Given this list of marker genes ARK2C, PDE4D, LXN, EGLN3, ADGRF1 (NCBI Gene Id 80118), ALDH1A2, PLPP5, GPD2, FYB1, DNAH9, DDIT4, SLC7A2, TMEM45A, AGRN, HLA-DOA, RNF19B, SP3, PFKL, MYCBP, SUCO, SMIM3, PTGFR (NCBI Gene Id 5737), DCN, SEMA4C, RPS6KA4, AQP9, SOD2, GARIN3, HIVEP3, HCAR1, OSBPL3, SAA2, BCKDHB, SMIM6, C6orf15, FCGR2B, ARRDC4, ZNF264 (zinc finger protein 264), GFOD1, RAD54L, MKS1, MLLT11, TNF, SLC4A7, TRIM7, PRR15, UBE2R2, JARID2, RIN1, FABP1, TMBIM4, CCSER1, ATP5ME (ATP synthase membrane subunit e), SUSD2, ABCB4, CFHR1, FAM162A, PIK3CG, KCNF1, KCTD11, F3, CLEC5A, PILRB, CA12, SSTR5, MAK16, MRPL45, FAM167B, CD14, PRKAR2B, DMXL2, SCHIP1, GPR35, CHIC2, SEMA7A, CD40, OR2C1, PTPN6, FKBP14, GNG10, LIF, ELL2, C19orf81, LUM, AHRR, SLC20A1, PTGES, CA4, AXL, FPR1, RAB27A, LOXL3 (NCBI Gene Id 84695), DSN1, MRPL52, MMS22L, NGF, FOXF2, ADAMTS7, SLC26A4, GLRX, S100A8, NKAPL, JAG1, METTL24, ZNF175, MMP2, DSTN, AK4, SAA1, CPB2, CFB, STX11, COL5A3, PILRA, SERPINB9, NFKBID, TOP1MT, DTX2 (NCBI Gene Id 57652), PMP22, SH3BP4, RCL1, USP53, PFKFB3 (6-phosphofructo-2-kinase/fructose-2,6-biphosphatase 3), ZNF771, UNC13C, ABHD16B, OPN1SW, PM20D1, GINM1, EDIL3, SRSF11, FBXO31, SRGN, NT5E, CNOT2, ABCA8, JMJD6, BTG3, CAVIN4, SOCS1, SLAMF9, VEGFA, MASTL, ACOT12, RPS27, GK, MAP3K12, NIPSNAP1, SPIN4, LRRC8D, MYL10 (NCBI Gene Id 93408), FJX1, RAP1GAP2, TMEM70, SAXO1, PRKAR1B, TNFAIP6, CST7, MCF2 (NCBI Gene Id 4168), EIF4E3, SNORC (secondary ossification center associated regulator of chondrocyte maturation), PRMT1, FBP1, ACOT7, HCLS1, PLCB3, CAND2, RUVBL2, AFF3, RDH12, HRG, BNC2, TCEA1, BMP1, HERC6, TGM1, IL1RN, CD72, DNAAF1, RBFOX1, SLC1A2, DGAT2, REL, MUC1 (NCBI Gene Id 4582, mucin 1, cell surface associated), TMA16, SGCE, MEX3B, ZNF296, SLC6A12, CA2, GJA1, IFNAR2, RHOQ, IFIH1, MAPKAPK2, DHRS13, CAMK2N1, IL20RB, ZNF804A, GPR18, here is a description of the gene set: Human Gene Set: GSE2585_CTEC_VS_MTEC_THYMUS_DN species: Homo sapiens Genes down-regulated in thymic epithelial cells: cortical (cTEC) versus medullary (mTEC). Gene expression in different thymic stromal cells and subsets thereof was analyzed in 6-12 week old wild type (C57BL/6) and Aire knock-out (mixed background) mice. Thymic stromal cells were purified by sequential enzymatic digestion (collagenase, collagenase/dispase and trypsin) followed by gradient centrifugation and FACS sorting. Sort criteria were as follows: dendritic cells (CD11c+, F4/80 -), macrophages (F4/80+, CD11c-), cTECs (CD45–/lo, CDR1/Ly51+, Ep-CAM+) and mTECs (CD45–/lo, CDR1/Ly51–, Ep-CAM+). mTECs of wild-type and Aire knock-out mice were further subdivided according to CD80 expression levels. For microarray analysis total RNA from thymic stromal cell samples of two independent experiments was pre-amplified and biotinylated by two rounds of cDNA synthesis and in vitro transcription. Fluorescence readings were evaluated by using Microarray Suite 5.0 software. from publication Derbinski J, Gäbler J, Brors B, Tierling S, Jonnakuty S, Hergenhahn M, Peltonen L, Walter J, Kyewski B (PMID 15983066)